The following is a description of a gene set: studied in species Mus musculus Mouse Gene Set: REACTOME_REGULATION_OF_PYRUVATE_DEHYDROGENASE_PDH_COMPLEX Regulation of pyruvate dehydrogenase (PDH) complex, and this is the list of marker genes: Pdk4, Pdhx, Dld, Pdp2, Pdp1, Pdk1, Pdha1, Dlat, Pdha2, Gstz1, Pdk3, Pdpr, Pdk2, Sirt4, Pdhb